The following is a description of a gene set: Human Gene Set: GOBP_NEGATIVE_REGULATION_OF_TOLL_LIKE_RECEPTOR_SIGNALING_PATHWAY studied in species Homo sapiens Any process that stops, prevents, or reduces the frequency, rate, or extent of toll-like receptor signaling pathway., and this is the list of marker genes: CACTIN, PDPK1, GPS2, LRRC14, MIR17 (microRNA 17), YWHAE, IRAK3, IRF4, SMPDL3B, NLRP2B (NCBI Gene Id 286430), NFKBIL1, NLRP6, GPR108, OTUD4, TYRO3, CD300LF, CD300A, ARRB2, LGR4, SARM1, RNF115, MIR19A